The following is a description of a gene set: studied in species Homo sapiens Abnormal increased size of the posterior cranial fossa. Enlarged posterior fossa Human Gene Set: HP_ENLARGED_POSTERIOR_FOSSA, and this is the list of marker genes: MTM1 (NCBI Gene Id 4534), SMARCD1, MAPKAPK5, ATP6V1A, SMARCC2 (SWI/SNF related, matrix associated, actin dependent regulator of chromatin subfamily c member 2), TCTN1, ESCO2, USP9X, POLR3A, CCDC22, FLVCR2, GLI3, COL4A1, B9D2, PGAP2, DAG1, ARID1A, CDC42, CTU2, KRAS, DYNC2I1, CEP290, APC2, EVC2, TCTN2, AP1S2, SOX4, C2CD3, WASHC5, PIEZO2, VPS51, PLCH1, AFF3, RNU12, RAC1, SLC35A2, NUP88, DYNC2I2, PPP1CB, GJB6, TIMMDC1, BCOR, CHD7, IL6ST, EBP, FLNB, RAB18, VRK1, TMEM216, BUB1, FAR1, BUB3, ZIC1 (NCBI Gene Id 7545), ATP6V1B2, KIAA0586, RAPSN, IGF2, KATNB1, MBD5, MID1 (midline 1), EXOSC8, EDEM3, NPHP3, IFT80, LARGE1, POMT1, DPH1 (NCBI Gene Id 1801), POMGNT1, NSD1, PLG, PI4K2A, BANF1, KCNQ1 (NCBI Gene Id 3784), ALG3, MAGEL2 (NCBI Gene Id 54551), TCTN3, CSF1R, EIF4A2, KIF7, FBXL4, DPF2, NEK8, SEMA3E, TUBB2A, PLPBP, GJB2, GPC4, ARMC9, SMG9, AHDC1, ATP6V1E1, OFD1, PMPCA (NCBI Gene Id 23203), CEP120, TXNDC15, PMM2, CEP57, HYLS1, ACADVL (NCBI Gene Id 37), POMK, EBF3, TBC1D24 (TBC1 domain family member 24), BRF1, SRPK3, DENND5A, SMARCE1, KIF21A, MAB21L1, RNU4-2, ARID1B, CLP1, OPHN1, BLTP1, CSPP1, CPT2, CRPPA, B4GAT1, PIGU, COG8, DYRK1A, NDUFC2, CC2D2A, DDX3X, SH2B1 (NCBI Gene Id 25970), SLC31A1, B9D1, SLC18A3 (solute carrier family 18 member A3), DYNC2H1, ALDH7A1, WDR35, B3GALNT2, RPGRIP1L, TMEM67, TRIP13, KIF5A, B4GALT1, CNOT3 (NCBI Gene Id 9756), ZFX, GTPBP2, TMEM231, KCNQ1OT1, FTO, CDH2, EVC, TUBB, PIGN, ABCC9, POLR1A, SUFU, TBCK, PITX1, RNF113A, CAMSAP1, POLR2A, SOX11, TMEM237, DPYSL5, FKTN, ASXL1, POMT2, POMGNT2, MUSK, RXYLT1 (ribitol xylosyltransferase 1), SMARCB1, ATP6V0A2, SLC5A6, WDR73, GPC3, FKRP, NRAS, ARID2, VPS35L, RPGRIP1, BUB1B, CPLANE1, DHCR7, MYOD1, NFU1, SMARCA4, COG1, TMEM138, FBXO28, CDKN1C, DPH2, WDR81, DOK7, TMEM107, DPH5 (diphthamide biosynthesis 5), PHGDH, SH3PXD2B, MKS1, MAN2B1, POGZ, FOXC1, ALDH18A1, PACS2, PRX, TUBA1A (NCBI Gene Id 95407), FGFR1, HRAS